The following is a description of a gene set: species: Homo sapiens Marker genes curated from the annotated cluster as represented in the Descartes Human Gene Expression During Development database. The gene expression program underlying the specification of human cell types is of fundamental interest. The study authors generated human cell atlases of gene expression and chromatin accessibility in fetal tissues. For gene expression, the study authors applied three-level combinatorial indexing to >110 samples representing 15 organs, ultimately profiling ~4 million single cells. The study authors leveraged the literature and other atlases to identify and annotate hundreds of cell types and subtypes, both within and across tissues. Our analyses focused on organ-specific specializations of broadly distributed cell types (such as blood, endothelial, and epithelial), sites of fetal erythropoiesis (which notably included the adrenal gland), and integration with mouse developmental atlases (such as conserved specification of blood cells). These data represent a rich resource for the exploration of in vivo human gene expression in diverse tissues and cell types. from publication Cao J, O'Day DR, Pliner HA, Kingsley PD, Deng M, Daza RM, Zager MA, Aldinger KA, Blecher-Gonen R, Zhang F, Spielmann M, Palis J, Doherty D, Steemers FJ, Glass IA, Trapnell C, Shendure J (PMID 33184181) Human Gene Set: DESCARTES_MAIN_FETAL_GRANULE_NEURONS, and this is the list of marker genes: KLHL29, SEZ6L-AS1, FGF5, GPC5-IT1, KCNA1, THSD7B, GRM4 (glutamate metabotropic receptor 4), KCNK9, UNC13C (NCBI Gene Id 440279), CCSER2, NAV2-IT1, ANKRD34C-AS1, SYNJ2, FRMPD3, LINC01830, PPP2R2C, NEO1, TAFA5, CDH7, KIF5C, LINC01324, DISP2